Given this list of marker genes ADAM10 (NCBI Gene Id 102), SH3GL2, FAM83B, ADAM12, SH3KBP1, STAM, LRIG1, PAG1, SRC, EPS15, PLCG1, SPRY2, GAB1, EREG, NRAS, CBL, ARHGEF7, AREG, HRAS (NCBI Gene Id 338029), CSK, EGF, SH3GL3, UBC, EPN1, PTPRK, ADAM17, EPGN, PIK3R1, AAMP, UBB, SHC1 (NCBI Gene Id 6464), KRAS, FAM83A, TGFA, STAM2, PTPN3, PTPN11, HGS, EGFR, PIK3CA, PXN, CDC42, HBEGF, UBA52, SOS1, SH3GL1, FAM83D, GRB2, PTPN12, SPRY1, BTC, EPS15L1, RPS27A, here is a description of the gene set: Human Gene Set: REACTOME_SIGNALING_BY_EGFR Signaling by EGFR species: Homo sapiens